Given this list of marker genes Vps4a, Exoc6b, Chmp2a, Dnm2, Spast, Vps4b, Chmp3, Exoc8, Chmp6, Chmp1a, Exoc4, Chmp1b2, Exoc1, Chmp7 (charged multivesicular body protein 7), Chmp2b, Dnm1l, Exoc7, Epn1, Dnm1, Exoc6 (exocyst complex component 6), Coro1c, Tmcc1, Exoc5, Sh3glb1, Chmp1b, Chmp4c, Chmp4b, Exoc2, Exoc3 (NCBI Gene Id 72678), Sh3gl2, Slc25a46, Chmp5, here is a description of the gene set: A process that is carried out at the cellular level which results in the separation of a single continuous membrane into two membranes. species: Mus musculus Mouse Gene Set: GOBP_MEMBRANE_FISSION